Given this list of marker genes Pclaf, Rpa1, Poli, Pold2, Mad2l2, Pcna, Uba7, Ufd1, Ubb, Pold1, Pold4, Rfc1, Pole2, Vcp, Pole, Rps27a, Usp43, Rev3l, Rchy1, Polk, Polh, Rfc3, Sprtn, here is a description of the gene set: This event has been computationally inferred from an event that has been demonstrated in another species.<p>The inference is based on the homology mapping from PANTHER. Briefly, reactions for which all involved PhysicalEntities (in input, output and catalyst) have a mapped orthologue/paralogue (for complexes at least 75% of components must have a mapping) are inferred to the other species. species: Mus musculus electronically inferred by orthology from the curated human pathway part of: DNA Damage Bypass Reactome Pathway: Translesion synthesis by Y family DNA polymerases bypasses lesions on DNA template